The following is a description of a gene set: studied in species Mus musculus Human Gene Set: MORI_MATURE_B_LYMPHOCYTE_DN The Emu-myc transgenic mouse has provided a valuable model for the study of B-cell lymphoma. Making use of gene expression analysis and, in particular, expression signatures of cell signaling pathway activation, we now show that several forms of B lymphoma can be identified in the Emu-myc mice associated with time of tumor onset. Furthermore, one form of Emu-myc tumor with pre-B character is shown to resemble human Burkitt lymphoma, whereas others exhibit more differentiated B-cell characteristics and show similarity with human diffuse large B-cell lymphoma in the pattern of gene expression, as well as oncogenic pathway activation. Importantly, we show that signatures of oncogenic pathway activity provide further dissection of the spectrum of diffuse large B-cell lymphoma, identifying a subset of patients who have very poor prognosis and could benefit from more aggressive or novel therapeutic strategies. Taken together, these studies provide insight into the complexity of the oncogenic process and a novel strategy for dissecting the heterogeneity of B lymphoma. from publication Mori S, Rempel RE, Chang JT, Yao G, Lagoo AS, Potti A, Bild A, Nevins JR (PMID 18922927) Down-regulated genes in the B lymphocyte developmental signature, based on expression profiling of lymphomas from the Emu-myc transgenic mice: the mature B, and this is the list of marker genes: GAS7, UCK2, MCM5, NUDT1, PLIN2, RGS2, MARCKS, CYCS, LXN, IL7R, SLC16A1, DHFR, PRPS1, H2AZ1, NEK2, ZBED3, PGLS, KIF2C, STMN1, SNRPB, CDKN3, NOTCH1, NDUFC1, MYL4 (NCBI Gene Id 4635), CDC45, EZH2, MPP1, SMARCA4, NCBP2, BRCA1, TXN, VPREB3, SOX4 (NCBI Gene Id 6659), IDH2, PAFAH1B3, ZFPM1, SNRPC, PREP, EWSR1, UFC1, LMNB1, ENPEP, HMGA1, CCNB1, GPAM, RAG1, TAX1BP3, MTHFD2, LGALS9, CAPN2, PLA2G12A, COX7A2, PSMD8, CD93 (CD93 molecule), HMGB2, CKS1B, SLC25A51, MYB, LITAF, DGCR6, DESI1, GFRA1, IRAG2, PRDX4, CDC25C, DNTT, RNASEH2B, CCNB2, HES6, PTGR1, H2AZ2, CCND3, RAG2, PSMC1, RRM2, ANLN